Given this list of marker genes HSPA12B, DNAJB6, NUP107, DNAJC2, FKBP4, HSPA12A, HSPA5 (NCBI Gene Id 3309), HSF1, ST13, HSPB1, NUP85, RPS19BP1, ATM, BAG1, HSPA4L, DNAJC7, MAPK1, MAPKAPK2, RPA1, HSBP2, HSPA2, BAG2, NDC1, COL4A6, RANBP2, NUP62, NUP43, HSPA13, HSPA1L, NUP214, NUP210, NUP155, HSPA7 (heat shock protein family A (Hsp70) member 7 (pseudogene)), SERPINH1, YWHAE, NUP88, TNFRSF21, HSPA14, MRPL18, DEDD2, MAPK3, NUP133, BAG3, POM121C, NUP58, HSPA4, NUP93, SIRT1, GML, HSPA8, POM121, TPR, NUP42, RAE1, BAG5, NUP160, RLN1, SEC13, HSPH1, NUP98, NUP50, HSPB2, AAAS, NUP54, NUP37, CRYBA4, NUP153, HSPA1A, NUP205, UBB, DNAJB1, RPA2, NUP35, HIKESHI, BAG4, NUP188, CCAR2, HSPA6, RPA3, SEH1L, HSPA1B, ATR, HSPA9, GSK3B, here is a description of the gene set: Reactome Pathway: Regulation of HSF1-mediated heat shock response part of: Cellular response to heat stress The ability of HSF1 to respond to cellular stresses is under negative regulation by chaperones, modulation of nucleocytoplasmic shuttling, post-translational modifications and transition from monomeric to trimeric state. species: Homo sapiens